The following is a description of a gene set: Human Gene Set: LOPEZ_EPITHELIOID_MESOTHELIOMA Top genes expressed higher in epithelioid than in sarcomatoid mesothelioma samples. from publication López-Ríos F, Chuai S, Flores R, Shimizu S, Ohno T, Wakahara K, Illei PB, Hussain S, Krug L, Zakowski MF, Rusch V, Olshen AB, Ladanyi M (PMID 16540645) Most gene expression profiling studies of mesothelioma have been based on relatively small sample numbers, limiting their statistical power. We did Affymetrix U133A microarray analysis on 99 pleural mesotheliomas, in which multivariate analysis showed advanced-stage, sarcomatous histology and P16/CDKN2A homozygous deletion to be significant independent adverse prognostic factors. Comparison of the expression profiles of epithelioid versus sarcomatous mesotheliomas identified many genes significantly overexpressed among the former, including previously unrecognized ones, such as uroplakins and kallikrein 11, both confirmed by immunohistochemistry. Examination of the gene expression correlates of survival showed that more aggressive mesotheliomas expressed higher levels of Aurora kinases A and B and functionally related genes involved in mitosis and cell cycle control. Independent confirmation of the negative effect of Aurora kinase B was obtained by immunohistochemistry in a separate patient cohort. A role for Aurora kinases in the aggressive behavior of mesotheliomas is of potential clinical interest because of the recent development of small-molecule inhibitors. We then used our data to develop microarray-based predictors of 1 year survival; these achieved a maximal accuracy of 68% in cross-validation. However, this was inferior to prognostic prediction based on standard clinicopathologic variables and P16/CDNK2A status (accuracy, 73%), and adding the microarray model to the latter did not improve overall accuracy. Finally, we evaluated three recently published microarray-based outcome prediction models, but their accuracies ranged from 63% to 67%, consistently lower than reported. Gene expression profiling of mesotheliomas is an important discovery tool, but its power in clinical prognostication has been overestimated. studied in species Homo sapiens, and this is the list of marker genes: LRRC1, CLDN15, UPK3B, BICDL1, ID4, ANXA9, GPR37, GRB7, PTPRF, ADCYAP1, LRP2, KLK11, UPK1B, COBL, ELMO3, HP, PRR15L